Given this list of marker genes Yap1, Poglut1, Bmpr1a, Foxc2, Htt, Epb41l5, Smad3, Tead1 (NCBI Gene Id 70301), Nckap1, Lef1, Tead2, Nup133, Wnt3a, Zic2, Dll3, Wnt5a, Tcf15, Smad2, Wnt11, Foxc1, Exoc4, Hnf1a, Fgfr1, Zic3, here is a description of the gene set: Mouse Gene Set: GOBP_PARAXIAL_MESODERM_DEVELOPMENT The process whose specific outcome is the progression of the paraxial mesoderm over time, from its formation to the mature structure. The paraxial mesoderm is the mesoderm located bilaterally adjacent to the notochord and neural tube. species: Mus musculus